Given this list of marker genes CCNB2, ASPM, TUBG2, ATRX, MYH9, DDB1, ESPL1, SKA1, SKA3, TUBG1, SKA2, PTEN, GOLGA2, MOS, NDC80, WASHC5, TUBB8, SEPTIN1, DCAF13, AURKA, PPP2R1A, FBXO5, here is a description of the gene set: studied in species Homo sapiens Human Gene Set: GOBP_MEIOTIC_SPINDLE_ORGANIZATION A process that is carried out at the cellular level which results in the assembly, arrangement of constituent parts, or disassembly of the microtubule spindle during a meiotic cell cycle.